Given this list of marker genes CCL1, LGMN, CXCL17, AIF1, CREB3, CCL5, PLA2G7, S100A14, CCR1, DEFB124, CXCL12, ANO6, SERPINE1, HMGB1, CX3CR1, TNFSF18, DEFB131A, CXCL10, S100A7 (NCBI Gene Id 6278), APP, FPR2, MOSPD2, CCR2, here is a description of the gene set: Human Gene Set: GOBP_POSITIVE_REGULATION_OF_MONOCYTE_CHEMOTAXIS Any process that increases the frequency, rate, or extent of monocyte chemotaxis. studied in species Homo sapiens